Given this list of marker genes AMZ2, ANKRD42, CELSR1, CTCFL, CPNE3 (copine 3), ABHD14B, COL13A1, ATP5PF, DUSP11, C1QL4, CNN2, ACRV1, AHSP, BOC, DSCR8, INIP, EMILIN1, EFHD1, C9orf40, BRIP1, DPT, EPC2, FDCSP, COL4A2, BTNL9, DSG1, EVC2, COQ10A, BNIP2, ARV1, EBF1, DDX11L2, CDH12, FAM209B, ANKRD30B, ANKRD18A, ZFAND4, CTSB, ARMCX1, ANKK1, CCDC190, DPP3, ARL6, DLC1, CLDN15, C1orf131, LLCFC1, SHLD1, CTSF, DHX58, CBFA2T3, ART4, DNAJB8, DGKK (NCBI Gene Id 139189), ACVR1, DHRS7C, ADA, CPXM1, APOD, SUPT20H, DTD1, CDC42SE2, DLEC1, CASP8AP2, CFAP184, DAG1, BHLHA9, APOA4, MIA2, CNGA2, SPATA6L, ENPP6 (ectonucleotide pyrophosphatase/phosphodiesterase 6), COQ2, C6orf58, BOLA3, B3GALT5-AS1, ANXA10, DEPDC1B, AMZ2P1, GARIN3, COLEC11, DLG1, AMTN, AMACR (alpha-methylacyl-CoA racemase), DNAJC9, ATF6, ADM2, CNR1, ELAVL2, SAXO2, TRABD2A, CWF19L1 (NCBI Gene Id 55280), CYP4F3, CHD5, CDX2, ADCY10, DIMT1, CYP1B1, UTP25, BMP5, MCEMP1, ASIC4, BAHCC1, DLGAP3, APOL5, CIBAR2, DUT, ATP10A, LINC02897, DNAJC24, CAMK4, METTL24, CXCL11, C1R, INSYN2A, DNAJC1, BRSK2, EPHA4, ACAD10, HEATR9 (HEAT repeat containing 9), ANGPT4, ATP6V1F (NCBI Gene Id 9296, ATPase H+ transporting V1 subunit F), AMER2, CCER1, C1S, C1QTNF8, ALS2CL, TEKTIP1, CD226, CIBAR1, FAM181A, ASPRV1, CD200R1, EVPL, DDX51, C1orf53, COL9A2, ARL4A, AMER1, ARHGAP33, ADH1B (alcohol dehydrogenase 1B (class I), beta polypeptide), ALKBH8, ASCL4, ELANE, CCDC178, LINC00518, ETV5, BMAL2, ALDH16A1, CA5BP1 (NCBI Gene Id 55393), CYP4A22, CCL19, ANKH, AANAT, CDC14A, ADH4, DDX25, RIPOR2, ADGRB3, COG5, CIAO2A, ADAMTS17, DMXL1, DRD4, CAMK2A, ATIC, AKAP12, CCL28, ALG13, CYP39A1, ABHD17AP4, TEFM, CRIM1, EFS, FAM9A, EDA, CRYBB2, MIX23, FA2H, DLGAP2, ERGIC1, C15orf32, ARL13A, IFTAP, COL16A1, ALKAL2, CALHM6, ATF7IP2, ACTMAP, AHI1, COL20A1 (NCBI Gene Id 57642), NYAP1, C11orf42, DMGDH, EPGN, CNOT6L, DNAJC27, EFCC1 (NCBI Gene Id 79825), CTSD, here is a description of the gene set: Genes up-regulated in thymocytes: double negative versus CD8 single positive. from publication Dik WA, Pike-Overzet K, Weerkamp F, de Ridder D, de Haas EF, Baert MR, van der Spek P, Koster EE, Reinders MJ, van Dongen JJ, Langerak AW, Staal FJ (PMID 15928199) species: Homo sapiens T cells develop from progenitors that migrate from the bone marrow into the thymus. Thymocytes are subdivided roughly as being double negative (DN), double positive (DP), or single positive (SP), based on the expression of the CD4 and CD8 coreceptors. The DN stage is heterogeneous and can be subdivided into four distinct subsets in mice based on the expression of CD44 and CD25. In human, three distinct DN stages can be recognized: a CD34+CD38−CD1a− stage that represents the most immature thymic subset and the consecutive CD34+CD38+CD1a− and CD34+CD38+CD1a+ stages. Human DN thymocytes mature via an immature single positive (ISP CD4+) and a DP stage into CD4+ or CD8+ SP T cells that express functional T cell receptors (TCR) and that exit the thymus. In this study, gene expression was measured in each of these nine stages. Human Gene Set: GSE22601_DOUBLE_NEGATIVE_VS_CD8_SINGLE_POSITIVE_THYMOCYTE_UP